The following is a description of a gene set: studied in species Homo sapiens Human Gene Set: HP_EEG_WITH_ABNORMALLY_SLOW_FREQUENCIES EEG with abnormally slow frequencies. EEG with abnormally slow frequencies, and this is the list of marker genes: CNKSR2, GABBR2 (NCBI Gene Id 9568), NECAP1, P4HTM, GABRA5, KCNA2, SCN8A, RNF13, SCN3A, GABRG2, KCNB1 (potassium voltage-gated channel subfamily B member 1), WWOX, HCN1 (hyperpolarization activated cyclic nucleotide gated potassium channel 1), GRIN2A, NUS1, LRPPRC, SZT2, CACNA2D1, ATP1A3, CLN8, FBXO28, MAPT, CHMP2B, CDK19 (cyclin dependent kinase 19), YWHAG, UBA5, VCP, AP3B2, SYNJ1, SLC2A1, FGF12, CLTC, DHDDS, PIGY, PACS2, TREM2, PARS2, GRN, NTRK2, CNTNAP2, FZR1, PPP3CA, KCNC2, GABRB2, SCN1A, CACNA1B, MTHFS, HID1, DNM1, LMNB1, SQSTM1, STXBP1, PLPBP, PSEN1, AARS1, DOLK, SLC6A1, OCA2, GNB1, CACNA1A, ATP1A2, SYNGAP1, DALRD3, CYFIP2, GRIN2D, TMEM106B, GABRA2, EEF1A2, KPTN, GRIA4, NEXMIF, DPAGT1, CDKL5, UBE3A, AP2M1, CELF2, ACTL6B, SLC13A5, TRAK1, CYP27A1, SLC38A3, SLC1A2, ALDH7A1, CHD2, MECP2, PLP1, ATP6V1A, FOXG1